Given this list of marker genes KARS1, VARS1, AARS1, KHSRP, EPRS1, GARS1, LIG1, NARS1, AIMP1, IARS1, YARS1 (tyrosyl-tRNA synthetase 1), HARS1, HARS2, QARS1, SARS1, CARS1, here is a description of the gene set: Genes in the cancer module 110. Human Gene Set: MODULE_110 species: Homo sapiens